Given this list of marker genes HOXA3 (NCBI Gene Id 3200), TBX1, GATA3, GCM2, FOXI3, CRKL, TGFBR1, here is a description of the gene set: Human Gene Set: GOBP_PARATHYROID_GLAND_DEVELOPMENT species: Homo sapiens The process whose specific outcome is the progression of the parathyroid gland over time, from its formation to the mature structure. The parathyroid gland is an organ specialised for secretion of parathyroid hormone.